Given this list of marker genes BACH2, PPP1R15B, PRRG1, PLAGL2, DMD, FBXO42, TRIM6, RUFY3, TGFB1I1, GATA6, ZNF512B, LPCAT3, ZBTB26, GNG5, IGF1R, TGFBR1, STK40, HAUS2, RDH10, GATM, NAP1L1, TDRD6, KLHL31, STIMATE (NCBI Gene Id 375346), NPHP3, NXPE3, PHTF2, KLF8, RIMOC1, HS6ST2, ERI2, RNF38, CYP20A1, LIN28B, TRIM71, HAND1, CFAP161, SLC9A6, CPEB3, SLC39A8, JAZF1, MDM4, ZFYVE26, PBX2, SALL4, SNX30, ESYT2, UTRN, TIMM23, IL10RB, TMEM121B, DISC1, OSBPL3, FIGNL2, AHR, NME6, HOXA7, NHLRC2, FBXO27, ALDH1L2, ASAH1, GUF1, SMAD6, ELMOD2, MED10, ZBTB5, XRCC5, CEP135, GXYLT1, SPRYD4, EMCN, ELP1, ZBTB34, ADRB2, SEPTIN7, HOXC8, GDF6, CNPY3, TRPM3, RPP25L, SORCS1, PRSS12, ECRG4, ZNRF3, ACVR1C, DNA2, COIL, HOXA9, MAP3K2, FOS, ADAMTS8, RGS16, SVIL, NBN, XPO7, GNB3, LHX1, RPGRIP1L, IQCB1, CBX5, MAP3K7CL, HOXB7, BMPR1A, BIN3, SEMA3A (NCBI Gene Id 63232, semaphorin 3A), REPIN1, STX3, here is a description of the gene set: Genes predicted to be targets of miRBase v22 microRNA hsa-miR-3927-3p in miRDB v6.0 with MirTarget v4 prediction scores > 80 (high confidence targets). studied in species Homo sapiens from publication Chen Y, Wang X (PMID 31504780) Human Gene Set: MIR3927_3P